The following is a description of a gene set: Genes down-regulated in MCF-7 cells (breast cancer) after knockdown of YBX1 by RNAi. species: Homo sapiens Human Gene Set: FUJII_YBX1_TARGETS_DN from publication Fujii T, Kawahara A, Basaki Y, Hattori S, Nakashima K, Nakano K, Shirouzu K, Kohno K, Yanagawa T, Yamana H, Nishio K, Ono M, Kuwano M, Kage M (PMID 18316615) In our present study, we examined whether nuclear localization of Y-box binding protein-1 (YB-1) is associated with the expression of epidermal growth factor receptors (EGFR), hormone receptors, and other molecules affecting breast cancer prognosis. The expression of nuclear YB-1, clinicopathologic findings, and molecular markers were immunohistochemically analyzed. The association of the expression of nuclear YB-1 and the molecular markers was examined in breast cancer cell lines using microarrays, quantitative real-time PCR, and Western blot analyses. Knockdown of YB-1 with siRNA significantly reduced EGFR, HER2, and ER alpha expression in ER alpha-positive, but not ER alpha-negative, breast cancer cell lines. Nuclear YB-1 expression was positively correlated with HER2 (P = 0.0153) and negatively correlated with ER alpha (P = 0.0122) and CXCR4 (P = 0.0166) in human breast cancer clinical specimens but was not correlated with EGFR expression. Nuclear YB-1 expression was an independent prognostic factor for overall (P = 0.0139) and progression-free (P = 0.0280) survival. In conclusion, nuclear YB-1 expression might be essential for the acquisition of malignant characteristics via HER2-Akt-dependent pathways in breast cancer patients. The nuclear localization of YB-1 could be an important therapeutic target against not only multidrug resistance but also tumor growth dependent on HER2 and ER alpha., and this is the list of marker genes: FUT8, H2AZ2, CLCN3, CDC6, DHFR, OIP5, CDC23, MCM6, ANKRD36, RAD54B, PLPBP, MBNL1, SHCBP1, POLR3F, NEK8, LMNB1, SSR1, ODC1, POLA2, SLC16A7 (solute carrier family 16 member 7), MELK, HADH, DNAJC3 (DnaJ heat shock protein family (Hsp40) member C3), UHRF1, MCM4, FEN1, UNG, NEIL3, XRCC3 (X-ray repair cross complementing 3), BRCA1, MCM10, NCBP2, COL2A1 (collagen type II alpha 1 chain), CHEK1 (checkpoint kinase 1), TIMELESS, FLNA, PTK2, HMGB3 (high mobility group box 3), SPC25, DBN1, JPH1, CENPN, DKK1, CDK8, GINS2 (GINS complex subunit 2), MAD2L2, GPX3, PARPBP, MCM2, CBX1, TRIP13, POLR1G, PLK4, CASP2, DTNA, UBE4B, HDLBP, TIMM8A, E2F7, FOXM1, SLC25A19, NUDT15, ZNF367, BAG2, MLLT11, PHKB, COTL1, FANCD2, PRIM1, BPGM, MGAT4A, KIF4A, TIMP3, ZWINT, PTGES, FBXO5, MDM1, ERCC8, CKS1B, POLE2, DUT, CXCR4 (NCBI Gene Id 93405), IPO5, SKP2, EIF4EBP2, NRM (NCBI Gene Id 11270), DEPDC1, CHAF1A, CDCA7, NCAPG2, SH3RF1, TARP, PDE3B, EI24, KIF23, RFC3, UBAC1, CDKN3, HELLS, NOP56, NUSAP1, RAD23B, RNASEH2A, OXCT1, DEPDC1B, CCNF (NCBI Gene Id 899), LIG1 (NCBI Gene Id 3978), METTL3, HIPK1, PHF19, NUP62, CCT5, ENAH, TAF15, H2AX, BUB1B, MASTL, PPP2R2C, YWHAH, MAD2L1, CXCL16, TIPIN, RFC5, TIAM1, BMP7, TTF2, UNC119B, FIGNL1, CDC25A, TWSG1, ATAD2, DMKN, CALU, RFC4, TBL1X, NSD2, CRISPLD1, RDH10 (retinol dehydrogenase 10), TK1, ASF1B, RAP2A, TCF19, PRR3, TOP2A, TRIO, PRKAR2B, MYBL2, CDC25C (cell division cycle 25C), CENPU, DTL, MCM5, RECK, ITPR1, PRPF40A, CENPK, ODF2, RAD51, SSU72, IL1RAP (NCBI Gene Id 3556), FANCI, DTYMK, VRK1, ITGAE, BRIP1 (NCBI Gene Id 83991), NCAPH, CDK2, FABP5, RRM2, ASPM, RRM1, VAPB, MSI2, SPA17, UBL3, MICB, PPP1R10, KBTBD6, SLC25A32, TAF9B, TFPI, CRIPT, EXO1, KIF11, DFFA (NCBI Gene Id 1676), MYBL1, PRKDC, SLC26A2, SSRP1, CDT1, MCM3, HNRNPL, IREB2 (iron responsive element binding protein 2), MCM7, ZBTB14